Given this list of marker genes Pth, Nmbr, Flt3l, Nmb, Gsk3b, Ocstamp, here is a description of the gene set: Any process that increases the rate, frequency, or extent of the multiplication or reproduction of osteoclasts, resulting in the expansion of an osteoclast cell population. studied in species Mus musculus Mouse Gene Set: GOBP_POSITIVE_REGULATION_OF_OSTEOCLAST_PROLIFERATION